Given this list of marker genes Tent5b, Cpa6, Macir, Fscn1, Sfmbt2, Azin2, here is a description of the gene set: studied in species Mus musculus from publication Cheng Y, Buffone MG, Kouadio M, Goodheart M, Page DC, Gerton GL, Davidson I, Wang PJ (PMID 17242199) TFIID is a general transcription factor required for transcription of most protein-coding genes by RNA polymerase II. TAF7L is an X-linked germ cell-specific paralogue of TAF7, which is a generally expressed component of TFIID. Here, we report the generation of Taf7l mutant mice by homologous recombination in embryonic stem cells by using the Cre-loxP strategy. While spermatogenesis was completed in Taf7l(-/Y) mice, the weight of Taf7l(-/Y) testis decreased and the amount of sperm in the epididymides was sharply reduced. Mutant epididymal sperm exhibited abnormal morphology, including folded tails. Sperm motility was significantly reduced, and Taf7l(-/Y) males were fertile with reduced litter size. Microarray profiling revealed that the abundance of six gene transcripts (including Fscn1) in Taf7l(-/Y) testes decreased more than twofold. In particular, FSCN1 is an F-action-bundling protein and thus may be critical for normal sperm morphology and sperm motility. Although deficiency of Taf7l may be compensated in part by Taf7, Taf7l has apparently evolved new specialized functions in the gene-selective transcription in male germ cell differentiation. Our mouse studies suggest that mutations in the human TAF7L gene might be implicated in X-linked oligozoospermia in men. Genes down-regulated in testis tissues upon knockout of TAF7L. Mouse Gene Set: CHENG_TAF7L_TARGETS